Given this list of marker genes Abcb7, Abcb10, Srrd, Clybl, Tmem14c, Tmem14a, Slc6a9, here is a description of the gene set: Any process that modulates the frequency, rate or extent of tetrapyrrole metabolic process. species: Mus musculus Mouse Gene Set: GOBP_REGULATION_OF_TETRAPYRROLE_METABOLIC_PROCESS